Given this list of marker genes GPR18, ABCB1, PDCD1, TBX19, PGM3, FAM13A, ROR2, MYOZ3 (NCBI Gene Id 91977), MYT1, CYP4F2, JADE3, ZNF157, GABRA1, USP20, DNAJC22, CTRL, ATP6V0A2, COL8A1, MPZL2, CXCL5, SYT5, CDH4, PCDHB17P, NOS2, PHOX2B, SLC6A2, SLC22A6, ADCYAP1, NXPE3, CAMK4, GCA, IL13RA1, GPR171, TRIO, FGF18, OCM, PAX7, PDPN, ATP10B, RNF24, LECT2, CRHR1, H3C6, F2RL3, IPO9, FUT1, KRT33A, SLC18A1, LPGAT1, PAX6, RSC1A1, POLR3F, IFNW1, HAAO, CYP2E1, CLCN3, GHRHR, ELAVL2, PPP1R12B, RYR1, MAGI1, POLR2K, MSL3, TFDP2, S100A5, COX6A2, AOC4P, CADM4 (cell adhesion molecule 4), ZBTB40, EXOC4, NR3C2, SLC4A3, KCNA5, CCN6, PRIM2, IVL, SOCS6, NHEJ1, PDE6A, NEB, SULT4A1, PHLDB1, TBXT, PRPS1L1, HEPH, ZNF133, AQP7, TRIM24, CHRNB4, IFNA14, SLC16A5, PSD, CNTN6, FZD5, MDM2, VSTM4, KRT86, ABCC8, RPS6KA5, HCRTR2, NCKIPSD, CTSB, JRKL, CEP162, DMPK, USP46, SPATA2, RB1CC1, R3HCC1L, DNAJC16, GPR19, ITGA2, BRINP3, KDR (kinase insert domain receptor), MAP2, PPP1R1A, BMP10, CDC42BPA, KPNA1, GNG4, FOSL1, FRY, LINC03124, PTPRB, IFNA8, CDR1, HSD3B2, ATP4B, FNTB, ZNF200, MAP3K1, IGKV7-3 (immunoglobulin kappa variable 7-3 (pseudogene)), IFNA1, CYP2C19, GPR15, OR10H3, EPHB2, TANC2, TSPAN2, BNIP1, LGI1 (leucine rich glioma inactivated 1), TLL1, IL11RA, REPS2, CYP2D6, SYNJ2, PTPRS, ATP2B2, IFNA10, FLRT2, HOXB7, NPFF, LPAR4, LRP6, ATP8A2, PSG1, IL13, SERPINA4, SLC17A1, BARX2, TPD52, ERC2-IT1, LILRA1, TTN, PAX9, COLGALT2, IL16, SOAT2, SLC4A4, ZNF141, AMMECR1, NTNG2, IFNA2, ARL3, RREB1, CALN1, PHF10, COL19A1, CDKL5, RBMXL1, PCM1, FBXL4, ZSCAN26, SCN7A (sodium voltage-gated channel alpha subunit 7), AFF2, COQ7, CFH, PIK3C2A, BRD4, MSH3, ZNF134, PIK3CB, FGF2 (fibroblast growth factor 2), NFAT5, ARFGEF2, NR1I2, WBP4, MINDY2, TSHB, SLC15A1, HSPA1L, STARD5 (StAR related lipid transfer domain containing 5), ULK2, DDX52, DMD, BRWD1, TNIK, SLC46A3, SRPK3, MFN1, DRD1, UBE4B, SGCD, POU6F1, GRIK5, ATP8B1, TENM4, NR2F1, GYS2, IL7, NOL4, MON2, LRP4, GCM1, RORB, MAGEA8, HOXD4, SIX6, SLC14A2, HOXC11, KLHL23, KNG1, BCL2L11, MAGEA9, CELA2B, PPM1E, ABCB10 (NCBI Gene Id 23456), THPO, P2RY10, NRTN, MC5R, KRT34, RUNX2, PDE4D, CHST1, MYH2, B4GALT6, PLA2R1, EYA1, RXRG, SPRR2C, MPP3, ZBTB14 (NCBI Gene Id 7541), ATF2, TTTY1, TPD52L1, ITIH3, PLEKHB1, ACKR1, PTPN20, CPZ, ZNF202, TSSK2, PRKCA, DGCR5, ADCY3, MLLT10, PAXIP1, CDH8, ISL1, CDC73, HNF1A, GLRA3, CMKLR2, ZP2, ASB4, SPA17, ABO, POLR1HASP, SLC26A4, GRIK1, C1orf216, IL4 (NCBI Gene Id 3565), TNK1, MAP2K7, CCL16, SLC17A7 (solute carrier family 17 member 7), STAG1, LDB3, FIG4, CA3, KRR1, ZNF33B, F2RL1, KLRC4, ZNF132, OPCML, SGPL1, GABRB2, PART1, DBT, CPEB3, SEMA6A, EDN3, ADAM20, MGA, CYP11A1, SUPT3H, HTR1E, EDIL3, ATF6B, CAMTA1, NOVA1, CPB2, AKAP3, SLC17A3, ERC1, NEDD4L, OTC, PLPPR4 (phospholipid phosphatase related 4), GUCY2F, CD8A, DAZL, PDE10A, FAS, CACNB1, ITIH1, TACC2, ZNF266, PPP2R5B, GLE1, ERCC4, FAM110B, FSHR, CD3E, CASP10, SIM2, SLC4A8, MPZL1, POU6F2, COL14A1, STAC, MASP2, GUCY2C, HTR2C, PTPRR, VPS35L, CACNA2D1, HTR1B, TMEM26, SLC33A1, RBBP7, RBMS3, RGS7, PAPPA2, RYR3, ITGBL1, ECM2, RAD51D, ADAM22, ATXN3, ADAMTSL3 (ADAMTS like 3, NCBI Gene Id 57188), NPAS2, BIRC5, NOTCH4, BRCA1, DRC3, ANXA10, PVR, OR2B6, LILRA4, APOBEC1, ST8SIA1, POFUT2, HTR3A, ADRA1A, FGA, HABP4, CCR3, GYPA, PRELID3A, LORICRIN, GJB5, SMYD3, ADGRL2, IL5, KRT2, here is a description of the gene set: Human Gene Set: MORF_RAD51L3 species: Homo sapiens Neighborhood of RAD51L3 RAD51-like 3 (S. cerevisiae) in the MORF expression compendium Neighborhood of RAD51L3